The following is a description of a gene set: Cohesin complexes mediate sister-chromatid cohesion in dividing cells but may also contribute to gene regulation in postmitotic cells. How cohesin regulates gene expression is not known. Here we describe cohesin-binding sites in the human genome and show that most of these are associated with the CCCTC-binding factor (CTCF), a zinc-finger protein required for transcriptional insulation. CTCF is dispensable for cohesin loading onto DNA, but is needed to enrich cohesin at specific binding sites. Cohesin enables CTCF to insulate promoters from distant enhancers and controls transcription at the H19/IGF2 (insulin-like growth factor 2) locus. This role of cohesin seems to be independent of its role in cohesion. We propose that cohesin functions as a transcriptional insulator, and speculate that subtle deficiencies in this function contribute to 'cohesinopathies' such as Cornelia de Lange syndrome. from publication Wendt KS, Yoshida K, Itoh T, Bando M, Koch B, Schirghuber E, Tsutsumi S, Nagae G, Ishihara K, Mishiro T, Yahata K, Imamoto F, Aburatani H, Nakao M, Imamoto N, Maeshima K, Shirahige K, Peters JM (PMID 18235444) species: Homo sapiens Human Gene Set: WENDT_COHESIN_TARGETS_UP Cohesin targets identified by ChIP-chip which were up-regulated after knockdown of CTCF and RAD21 by RNAi., and this is the list of marker genes: STK3, VTA1, RND3, PFDN4, TRMT11, USP25, MEF2A, ELF2, FRA10AC1, AGTPBP1, PLEKHA5, PTK2 (protein tyrosine kinase 2), POLR2M, REEP3, PIK3R3, EXOC6, OXR1, ATG5, JMJD1C (jumonji domain containing 1C), MKLN1, TLK2, SEPTIN7, TOP2B, ALCAM, FUT8, ASPH, CAST, SREK1, TNPO1 (transportin 1), CAMSAP2, YOD1, GOLGA8A